Given this list of marker genes Xpo1, Mapkapk5, Psma1 (proteasome subunit alpha 1), Psma5 (NCBI Gene Id 26442), Prkaca, Psmd12, Psma3, Mapk4, Psma4, Psma7, Psmb7, Psmc6, Psmb4, Cdc14a, Psmb6, Septin7 (NCBI Gene Id 235072), Psmd13, Psmd1, Ubb, Hspb1, Pak3, Psmc3, Psma2, Psma6, Psmc1, Psmc2, Psmd7, Psmc5, Cdk1, Dnajb1, Cdc42, Rps27a, Prkacb, Psmb5, Psmc4, Psmd6, here is a description of the gene set: This event has been computationally inferred from an event that has been demonstrated in another species.<p>The inference is based on the homology mapping from PANTHER. Briefly, reactions for which all involved PhysicalEntities (in input, output and catalyst) have a mapped orthologue/paralogue (for complexes at least 75% of components must have a mapping) are inferred to the other species. part of: MAPK family signaling cascades studied in species Mus musculus electronically inferred by orthology from the curated human pathway Reactome Pathway: MAPK6/MAPK4 signaling